The following is a description of a gene set: species: Homo sapiens Genes up-regulated in comparison of dendritic cells (DC) versus Th1 cells. Human Gene Set: GSE3982_DC_VS_TH1_UP from publication Jeffrey KL, Brummer T, Rolph MS, Liu SM, Callejas NA, Grumont RJ, Gillieron C, Mackay F, Grey S, Camps M, Rommel C, Gerondakis SD, Mackay CR (PMID 16474395) In the present study we used Affymetrix oligonucleotide microarrays to produce gene transcription profiles for the major leukocyte types in humans. This comprehensive dataset enabled us to not only establish which genes were expressed in each leukocyte type, but also which genes were expressed in each subset after activation. The used of a comprehensive dataset of gene profiles from all the major human leukocyte subsets enabled a novel and powerful means for identification of genes associated with single leukocyte subsets, or different immune paradigms., and this is the list of marker genes: PLXNB2, HLA-DQB2, DNASE1L1, PLAU, ACOX2, ARHGEF40, UBAP1, ZNF155, GAS2L1, TMBIM1, CTSS, NEK9, IFNAR2, RGCC, CDC42BPB, RIOK3, PSAP, UQCC1, MKKS, SPRED2 (NCBI Gene Id 200734), DRAM1, SEL1L, SV2B, AKR1C3, FCER1A, CAPG, AKR1A1, EPHX3, LINC00667, SMAD6, BCL2L2, CD1D, VPS8, PGLYRP1, CSDE1, NAA60, CNOT4, PEPD, PEA15, PLXNA1, HPCAL1, IFFO1, CFD, PRDX6, TET3, GPT, ZNF804A, BLVRA, CCN3 (NCBI Gene Id 4856), NPL, TGFA, TAL1, RUFY3, DSC2, MYOF, FCGR2C, CAPN3, TMEM9B, C5, CYP27B1, SLC22A4, TRAM1, NHLRC2, GNAQ, ALDH1A1, CYB5A, SOCS6, SCPEP1, TPP1, ADORA2B, CCDC106, SESN1, SEPTIN2, NAGPA, MRAS, SLC9A6, FAM114A1, TTC13, CTNS, SCARB1, KCNB2, IGSF6, LRRFIP2, C1orf54, CHI3L1, C11orf71 (NCBI Gene Id 54494), C1QA, PTGDS, SLC15A3, KYNU, C1orf115, SRPK2, INHBB, C11orf21, MAOA, VCL, TLR2, RHEB, SNX13, CUX1, RGS2, LYL1, CTNNAL1, ADA2, PDE8A, KCNJ1, ZSCAN32 (NCBI Gene Id 79229), RASAL2, MSTN, THBD (thrombomodulin), LMBRD1, PARM1, GPNMB, SYT17, FCGR2B, ARRB1, STAT6, NFKBIE, TBC1D8, C5AR1, TGFBI, PKD1L1-AS1, METTL1, FPR3, CD52, GPC1, ADPGK, H3C12, CUL4A, ALCAM, CLEC10A, EPB41L1, PLXND1, CES3, SPINT2, MVB12B, SLC27A3, RENBP, MERTK, ACVR2A, LRRC8D, CLCN7, ARL15, SLC6A12, TREM2, GCGR, NPC2, CSTB, PTK2, TRDMT1, BCL6, PILRA, FGR, IL18, ROBO3, PDE5A, CCL17, SPI1, CLN8, SIDT2, ANPEP, VPS41, FRAT2, PDGFC, MCCC2, GAS7 (NCBI Gene Id 8522), LILRA2, FLT1, CTSL, CLIP4, PARP12, TACSTD2, TSG101, CD36, TTC3, TENT5A, CORO2A, SH3BGRL, PZP, PCOLCE2, ADAP2, FYCO1, ABHD6, CR1, TMEM127, SMIM7, LDLRAP1, STEAP3, FBXO21, PROC, TRAPPC9, GBX2, CRTAP, ANXA1, PLEKHS1, PCK2, DNASE2B, SCARB2, CRYBG3, NPPC